The following is a description of a gene set: Mouse Gene Set: GOMF_HISTONE_H4K20_METHYLTRANSFERASE_ACTIVITY studied in species Mus musculus Catalysis of the reaction: S-adenosyl-L-methionine + histone H4 L-lysine (position 20) = S-adenosyl-L-homocysteine + histone H4 N6-methyl-L-lysine (position 20). This reaction is the addition of a methyl group to the lysine residue at position 20 of the histone H4 protein., and this is the list of marker genes: Prdm6, Setd4, Kmt5a, Prdm9, Kmt5c, Nsd1, Smyd5, Kmt5b